The following is a description of a gene set: The gene expression program underlying the specification of human cell types is of fundamental interest. The study authors generated human cell atlases of gene expression and chromatin accessibility in fetal tissues. For gene expression, the study authors applied three-level combinatorial indexing to >110 samples representing 15 organs, ultimately profiling ~4 million single cells. The study authors leveraged the literature and other atlases to identify and annotate hundreds of cell types and subtypes, both within and across tissues. Our analyses focused on organ-specific specializations of broadly distributed cell types (such as blood, endothelial, and epithelial), sites of fetal erythropoiesis (which notably included the adrenal gland), and integration with mouse developmental atlases (such as conserved specification of blood cells). These data represent a rich resource for the exploration of in vivo human gene expression in diverse tissues and cell types. Marker genes curated from the annotated cluster as represented in the Descartes Human Gene Expression During Development database. Human Gene Set: DESCARTES_MAIN_FETAL_MYELOID_CELLS from publication Cao J, O'Day DR, Pliner HA, Kingsley PD, Deng M, Daza RM, Zager MA, Aldinger KA, Blecher-Gonen R, Zhang F, Spielmann M, Palis J, Doherty D, Steemers FJ, Glass IA, Trapnell C, Shendure J (PMID 33184181) studied in species Homo sapiens, and this is the list of marker genes: MANCR, LILRB2, DMXL2, TYROBP, CD207, SDS, FPR3, S100A12, HBEGF, IFNAR2 (NCBI Gene Id 3455), RNASE6 (NCBI Gene Id 6039), MIR3945HG, C1QB, IFI30, WWP1, TNFAIP8L2, CLEC7A, TIMD4, PLAUR, LILRA1, MARCO, CMKLR1, PELATON, CD209, RETN, SIGLEC7, NLRP3, LILRB3, RILPL2, RNPS1P1, CD33, MS4A6A, CD14, VENTX, RN7SL368P, C1QC, STAB1, CD180, C5AR2, SCIMP, CD163L1, C1QA, RRP12, SIGLEC12, CALHM6-AS1, SPI1, CR1, CLEC4A, NAMPT (NCBI Gene Id 10135), CD163, MS4A4E, CD86, LGMN, AIF1, ABI3, SAMHD1, MTND5P14, CCDC26, FCAR, FRMD4B, SH2B3, C1orf162, LILRA6, TLR8, NCF4, CD300C (NCBI Gene Id 10871), LINC01678, CD300LB, IL10, MAN2B1, SIGLEC16, MS4A4A (membrane spanning 4-domains A4A, NCBI Gene Id 95933), JAML, SNX6, MS4A7, SIGLEC5, SIGLEC1, SRGN, RGL1, LILRA5, LRRC25 (NCBI Gene Id 126364), LILRB1, THEMIS2, AOAH-IT1, ENSG00000253557, MCOLN1, CLEC10A, GPR183, FPR2, HK3, SIGLEC9, PYCARD, LINC01478, HLA-DQB1-AS1, CABP4, LILRB5, HMOX1, CTSS